Given this list of marker genes KRT14, POGLUT1, HAVCR2, KIT, MEFV, COL7A1, PTPN6, XPA, KRT5, POFUT1, PSENEN, DCLRE1C, here is a description of the gene set: Erythematous papule Human Gene Set: HP_ERYTHEMATOUS_PAPULE A circumscribed, solid elevation of skin with no visible fluid that is reddish (erythematous) in color. studied in species Homo sapiens